Given this list of marker genes TALDO1, HMGN1 (high mobility group nucleosome binding domain 1), DENND1A, MTCH1, PSTPIP1, ANXA7, SDHC, NUP205, SCCPDH, AAAS, BCAT2, RTN3, HADHA, SAMSN1, AURKA, XPO1, GZMB, TRAF3IP3, CHMP7, IL32, QPRT, GAPDH, TBC1D10C, PFKP, FES, EEF1A1, SLC25A3, CEBPZ, TIMM17A, RHOA, ARL6IP5, OXA1L, ATP5F1B, COX4I1, SLC25A6, CD7, MFF, ATP5MG (NCBI Gene Id 10632), FAS, MFAP1, MX1, EIF3F, FUS, RAC2, RIT1, BNIP3L, CASP4 (caspase 4), CCT5, CD74, METAP1, SCAMP3, UBXN4, HCCS, GPI, UBE2R2, CASP1, RIPK3, RPL10A, SYMPK, HLA-A, APH1B, ATP1A1, RHOH, CYTH2, AP5Z1, MARK2, TOMM20, ELOVL1, CD48, VDAC1, DDHD2, TMEM106C, CYSLTR1, MSH2, BAX, TMEM35B, RALB, CYFIP2, MTCH2, RPLP0 (NCBI Gene Id 6175), HSPA8, GNAS, MTO1, VCF1, MATK, STX4, NINL, here is a description of the gene set: species: Homo sapiens Functional annotation of complex genomes requires the development of novel experimental platforms with increased capacity. Here, we describe a high-throughput system designed to identify cDNAs whose overexpression induces morphologically distinct cell death modalities. The methodology incorporates two robotized steps, and relies on coexpression of library clones with GFP to reveal the morphological features presented by the dying cells. By using this system we screened 135 000 cDNA clones and obtained 90 independent molecules. Interestingly, three death categories were identified, namely; apoptotic, vacuolated and autophagic. Among the pro-apoptotic clones, we found four members of the mitochondrial carrier family: the phosphate and adenine nucleotide (type 3) transporters, and the mitochondrial carrier homologs (MTCHs) 1 and 2. Expression of these molecules induced cytochrome c release and caspase-9-dependent death. One of them, the phosphate carrier, was able to interact with members of the permeability transition pore complex ANT1 and VDAC1, and its binding to ANT1 was stabilized in the presence of apoptotic activators. Depletion of this carrier by siRNA delayed cytochrome c mobilization and apoptosis. These results attribute a previously undescribed apoptotic function to the phosphate carrier and, more generally, suggest that a common property of various mitochondrial transporters was exploited during evolution to regulate apoptosis. Human Gene Set: ALCALA_APOPTOSIS Genes able to induce cell death in an expression cDNA library screen. from publication Alcalá S, Klee M, Fernández J, Fleischer A, Pimentel-Muiños FX (PMID 17621274)